The following is a description of a gene set: Human Gene Set: MIR31_3P studied in species Homo sapiens from publication Chen Y, Wang X (PMID 31504780) Genes predicted to be targets of miRBase v22 microRNA hsa-miR-31-3p in miRDB v6.0 with MirTarget v4 prediction scores > 80 (high confidence targets)., and this is the list of marker genes: ELAPOR1, FCHSD2, NT5DC1, SEPTIN10, GABBR2, ZDBF2, TDP1, PLEKHB2, CREB5, DDHD2, C6orf62, GPCPD1, TENT5A, SEC31A, NKRF, AS3MT (arsenite methyltransferase), KIAA0232, CDH13, BTBD10, BACH1, POLR2K, BCL10, VPS13A, PRSS23, KRT36, ARRDC3, IL15, AKAIN1, KRTAP3-3, USP9X, ELAVL4, ELOC, HAUS4, ZNF236, VAT1L, NAA25 (NCBI Gene Id 80018), MED12L, CHMP4B, HTR3E, SIPA1L2, GRIN2A, SHCBP1, MBD4, MASP1, EHBP1, KCNK10, SLC10A7, RCOR1, GRHL1, PAFAH1B2, RHOXF2B, ZMYM5, GPR137C, TRIT1, FRS2, RXFP1, RHOXF2, DAPK1, SYBU, AIFM2